The following is a description of a gene set: Mouse Gene Set: REACTOME_ERBB2_REGULATES_CELL_MOTILITY studied in species Mus musculus ERBB2 Regulates Cell Motility, and this is the list of marker genes: Nrg1, Ereg, Erbb3, Erbb2, Egf, Memo1, Egfr, Erbb4, Hbegf, Nrg3, Rhoa, Diaph1 (NCBI Gene Id 28110), Btc (betacellulin, epidermal growth factor family member)